Given this list of marker genes Srl, B3galt1, Mbd4, Glis2, Spry1, Ntf3, Pcmtd2, Yap1, Tipin, Nfib, Ppp1r3a, Tsga10, Edrf1, Fa2h, Edil3, Ifrd1, Pan3, Necab1, Il12a, Caskin1, Pcsk6, Slc30a10, Spink14, Pitx2, Crebrf, Arhgap24, Map3k1, Tmem236, Prkci, Tmtc3, Adgrg2, Ankrd49, Pnpt1, Gramd2b, Elf2, Lsm5, Smad7, Hnrnpu, Tent5a, Bcl11b, Kdm7a, Tmem170, Jph1, Zfp367, Fnip1, Mprip, Tgfbi, Pja2, Sox5, Scml2, Ndufv2, Dmrtc2, Osr1, Rasgrp1, Matn2, Armcx5, Fgd4, Pcbp2, Ppp1r3b, Yod1, Acvr2a, Nkiras1, Armcx1, Fgf18, Il21, Rmnd5a, Peli1, Fasl, Nectin3, Gm4894, Zfp27 (zinc finger protein 27), Zdhhc17, Dusp8, Ipo11, Spry2, Ccl1, Fmn1, Ccl20, Pik3r1, Epha4, Nfia, Pbrm1, Hnrnpk, Mreg, Stag2, Ubr3, Akap6, Bcl7a, Ski, Dvl2, Ranbp3l, Cpeb3, here is a description of the gene set: studied in species Mus musculus Genes predicted to be targets of miRBase v22 microRNA mmu_miR_590_5p in miRDB v6.0 with MirTarget v4 prediction scores > 80 (high confidence targets). Mouse Gene Set: MIR_590_5P from publication Chen Y, Wang X (PMID 31504780)